The following is a description of a gene set: species: Homo sapiens Human Gene Set: GOBP_NEGATIVE_REGULATION_OF_CARDIAC_MUSCLE_CONTRACTION Any process that stops, prevents, or reduces the frequency, rate or extent of cardiac muscle contraction., and this is the list of marker genes: PIK3CG, BIN1, ADCY10, MIR30E, SRI, ZC3H12A